Given this list of marker genes AMER1, here is a description of the gene set: Reactome Pathway: Deletions in the AMER1 gene destabilize the destruction complex species: Homo sapiens part of: Signaling by AMER1 mutants Genomic deletions of the entire AMER1/WTX gene occur in about 12% of Wilms tumors, a pediatric kidney cancer. Nonsense and missense mutations have also been identified. AMER1 is a known component of the destruction complex and interacts directly with beta-catenin through the C-terminal half. siRNA depletion of AMER1 in mammalian cells stabilizes cellular beta-catenin levels and increases the expression of a beta-catenin-dependent reporter gene, suggesting that AMER1 is a tumor suppressor gene.